Given this list of marker genes Onecut2, Pkd1, N6amt1, Adam23, Arhgef2, Ap5s1, Rnf41, Dlk1, Fgf5, Mlxip, Trim33, Odr4, Slurp1 (NCBI Gene Id 80539), Pdlim5, Grin2b, Tmed6, Rgs9bp, Cdv3 (carnitine deficiency-associated gene expressed in ventricle 3), Jmjd8, Ssb, Ppp2r1a, Hdac2, Cxxc4, here is a description of the gene set: species: Mus musculus Genes predicted to be targets of miRBase v22 microRNA mmu_miR_7672_5p in miRDB v6.0 with MirTarget v4 prediction scores > 80 (high confidence targets). from publication Chen Y, Wang X (PMID 31504780) Mouse Gene Set: MIR_7672_5P